The following is a description of a gene set: species: Mus musculus ESC pluripotency pathways Mouse Gene Set: WP_ESC_PLURIPOTENCY_PATHWAYS, and this is the list of marker genes: Wnt10b, Bmpr1b, Mapk7, Egfr (epidermal growth factor receptor), Fzd5, Mapk1, Grb2, Mdm2, Smad1, Fgf7, Fgf1, Fgf4, Bmpr1a, Fgfr2, Wnt3, Mtor, Smad6, Wnt7a, Dvl3, Smad7, Myc, Map2k5, Fgf15, Eras, Fgf13 (fibroblast growth factor 13), Wnt16, Akt3, Fzd2, Egf, Fgf3, Wnt5a, Map2k1, Jak1, Lrp5, Wnt2b, Pik3r2, Fgf14, Bmpr2, Bmp4, Fgfr3, Fgf23, Smad4, Fzd3, Pdgfb, Hras, Fgf22, Fgf6, Mapk12, Acvr1, Gab1, Mapk6, Fzd6, Fzd1, Fgf2, Wnt1, Fgf21, Map2k6, Araf, Apc, Sos1, Fzd7, Ctnnb1, Fgfr1, Jun, Gsk3b, Smad5, Map2k3, Axin1, Hnf1a, Raf1, Pten, Wnt2, Il6st, Wnt5b, Dvl2, Map2k2, Fgfr4 (fibroblast growth factor receptor 4), Wnt9b, Wnt3a, Wnt6, Fzd8, Pdgfra, Fzd4, Pdgfa, Stat3, Lrp6, Fgf9, Pdgfrb, Wnt7b, Wnt11, Akt1, Dvl1, Fgf16, Wnt4, Fgf18, Ptpn11, Selenop, Lifr, Fgf17, Braf, Actr2, Nog, Wnt10a, Fgf10 (NCBI Gene Id 14165), Lif (NCBI Gene Id 16878), Fgf20, Fgf12, Fos, Fgf8, Fzd9, Pik3cd, Elk1, Smad9, Mapk4, Akt2, Fgf5